The following is a description of a gene set: Human Gene Set: HP_CAVUM_SEPTUM_PELLUCIDUM species: Homo sapiens Cavum septum pellucidum If the two laminae of the septum pellucidum are not fused then a fluid-filled space or cavum is present. The cavum septum pellucidum is present at birth but usually obliterates by the age of 3 to 6 months. It is up to 1cm in width and the walls are parallel. It is an enclosed space and is not part of the ventricular system or connected with the subarachnoid space., and this is the list of marker genes: RNU4-2, RAB5IF, PPP2R5D, EBF3, RAP1B, MED25, BANF1, PPP1R21, MAPKAPK5, ALG12, MUSK, MAPK1, CTBP1, PIK3CA, LRRC32, POLR1A, STT3A, RNF125, MITF (melanocyte inducing transcription factor), RBM8A, NKX2-1, SMG8, PAFAH1B1, PACS1, APC2 (APC regulator of WNT signaling pathway 2), ZSWIM6, TUBB2B, LETM1, CPLX1, RRAGC, FGFRL1, PCGF2, NSD1, NSD2